Given this list of marker genes PRKN, NDUFC2, ACMSD, PINK1, TMSB4X, ENO1, ADCY10, GUCA1ANB-GUCA1A, ANTKMT, ATPSCKMT, MAP2K1, PPARA, VCP, PARP1, PID1 (phosphotyrosine interaction domain containing 1), MIR675, TAFAZZIN, RD3 (NCBI Gene Id 343035), TREM2, GUCA1A, IL4, ATP5IF1, DNAJC30, STAT3, SPHK2, here is a description of the gene set: Any process that modulates the frequency, rate or extent of the chemical reactions and pathways resulting in the formation of nucleotides. Human Gene Set: GOBP_REGULATION_OF_NUCLEOTIDE_BIOSYNTHETIC_PROCESS species: Homo sapiens